Given this list of marker genes Daam1, Pfn2, Tln2, Arhgef7, Clasp2, Pls3, Pclo, Cap2, here is a description of the gene set: Mouse Gene Set: GOBP_PRESYNAPTIC_CYTOSKELETON_ORGANIZATION species: Mus musculus A process that is carried out at the cellular level which results in the assembly, arrangement of constituent parts, or disassembly of cytoskeletal structures and their associated proteins in the presynaptic cytoskeleton.